Given this list of marker genes VIM, SOX11, UNC45B, LIM2, SIX3, WNT2, TGFBR1, FAT1, SPRED2, CRYGD, TBC1D32, WNT2B, GJE1, SOX1, HIPK2, SPRED1, CRYGB, BIRC7, NECTIN1, MEIS1, NF2, NECTIN3, CRYBA2 (NCBI Gene Id 1412), CTNS, SKI, PLAAT1, ATF4, NTRK3, CRYGA, TBC1D20, EPHA2, TMOD1, CTNNB1, HIPK1, SHROOM2, KDM5B, CRYBB1 (NCBI Gene Id 1414), WNT5A (Wnt family member 5A), WNT7A, MED1, SLITRK6, ABI2, CRYAB, MIP, SIX5, CRYBA4, CRYAA, HSF4, BFSP1, PYGO2, FRS2, CDKN1B, CRYBG3, CRYGN, CRYBB2, CRYGS, SMAD3, BFSP2, CRYGC, SPRED3, FZR1, PROX1, SPRY2, WNT7B, TGFB1, FOXE3, NDP (NCBI Gene Id 4693), GATA3, NHS, FGF2, SPRY1, PAX6, CRYBA1, TDRD7, WNT5B, MAF, CDKN1C, GJA8, CRYBB3, BCAR3, SKIL, PLAAT3, LENEP, PITX3, LCTL, CITED2, ADAMTS9, DLG1, ZEB2, CDON, TGFBR2, BMP4, here is a description of the gene set: Human Gene Set: GOBP_LENS_DEVELOPMENT_IN_CAMERA_TYPE_EYE studied in species Homo sapiens The process whose specific outcome is the progression of the lens over time, from its formation to the mature structure. The lens is a transparent structure in the eye through which light is focused onto the retina. An example of this process is found in Mus musculus.